The following is a description of a gene set: Catalysis of the transfer of an amino group to an acceptor, usually a 2-oxo acid. Human Gene Set: GOMF_TRANSAMINASE_ACTIVITY species: Homo sapiens, and this is the list of marker genes: MGAT4A, OAT, GOT2 (NCBI Gene Id 2806), GPT2, GFPT1, KYAT3, ACCS, BCAT2, PSAT1, AGXT, GPT, KYAT1, PHYKPL, ABAT, TAT, GOT1L1, GFPT2, AMT, AADAT, ETNPPL, AGXT2, BCAT1, GOT1, CISD1, ACCSL